Given this list of marker genes PABPC1, SYNCRIP, PAIP1, CSDE1, HNRNPD, here is a description of the gene set: Human Gene Set: GOCC_MCRD_MEDIATED_MRNA_STABILITY_COMPLEX studied in species Homo sapiens A protein complex that binds to, and promotes stabilization of, mRNA molecules containing the major coding region instability determinant (mCRD) by bridging the mCRD domain and the poly(A) tail of the mRNA. In human, it consists of CSDE1, HNRPD, PABPC1, PAIP1 and SYNCRIP.